The following is a description of a gene set: Any process that activates or increases the frequency, rate or extent of cell-substrate junction organization. Mouse Gene Set: GOBP_POSITIVE_REGULATION_OF_CELL_SUBSTRATE_JUNCTION_ORGANIZATION studied in species Mus musculus, and this is the list of marker genes: Tek, Tsc1, Lims1, Rac1, Map4k4 (NCBI Gene Id 98646), Itgb1bp1, Myh9, Dusp3, Iqsec1, Vegfa, Nrp1, Smad3, Cfl1, Rock1, Fmn1, Poldip2, Myoc, Enpp2, Fermt2, Hrg (histidine-rich glycoprotein), Sdc4, Kdr, S100a10, Abl1, Thy1 (NCBI Gene Id 21838), Ptpn11, Arf6 (ADP-ribosylation factor 6), Mapre2, Iqgap1, Ppm1f, Col16a1, Wnt4, Pik3r1, Ptprj, Epb41l5